Given this list of marker genes Blcap, Bbc3, Fcer1g, Actb, Mrpl17, Furin, Hspa9, Rps6kc1, Eif2s3x (NCBI Gene Id 26905), Ctrc, Frmd8os, Lrrfip2, Xpnpep3, Casp4 (caspase 4, apoptosis-related cysteine peptidase, NCBI Gene Id 12363), Mir1931, Sirt6, Sema4a, C030005K06Rik, Gsr, Lyrm1, Zkscan5, Smarca5, Ticam2, Tbck, Snord13, Hivep1, Nfkbia, Slc2a3, Niban3, C1qc, Pno1, Gata3un, Tgif1, Eif4g2, Napsa, Tpbg, Relb, Plscr1, Zmiz1os1, Ptgs2os, Arid5b, Osgin1, Ddx31, Gm16794, Zfp811, Tnfaip8, Sh3bp5l, Mir8105, Olr1, Clec4e, Cnbd2, Gbp6, Cactin, Thbs1, B430010I23Rik, Rmrp, Gm13986, Tm9sf1, Ccnl1, Mnt, Med13, Ifnb1, Utp3, Trps1, Nod2, Gch1, Uqcrc2, Gbp4, Dennd4a, Zbtb18, Opa3, Lrmda, 4931440P22Rik, Fadd, Itgb5, Pdap1, Tubgcp4, Atp5mc1, Il2rg, Adgre1, Ccni, Ogfr, Adamts4, Kcnh4, Tnip3, Ikzf4, Ubl7, Lmna, Manbal, Mir155hg, Slc29a1, 4930592C13Rik, Txlnb, Tfeb, Creg2, Zfp429, Zfp91, Ist1, Tnip1, Plpp1, Itpkc, Sephs2, Eif4enif1, Srd5a1, Kat2b, Pcdh7, Gm7804, Neurl3, Mir6236, Tnfsf13, Prex1, Iqcg, Ptch1, Oip5, Igsf6, Zbtb21, Gm27003, Ank1, Pak1ip1, Mideas, Bud31, Lrrc49, 9130230L23Rik, C3, Lrrc63, Slc30a6, Ptges, Etv6, Irak3, Hectd1, Cacybp, Acaa1a, Tmem39a, Golga5, Zc3h7a, Csf1r, Cox18, Ric8a, Zc3h12a, Anp32a, Irgq, Actr2, Rbm47, Gramd1b, Slc35b1, Phf14, Prdx6, Ccl6, Eml6, Hk1, Gm16675, Eftud2, Hif1a, Pan3, Il3ra, Cited2 (Cbp/p300-interacting transactivator, with Glu/Asp-rich carboxy-terminal domain, 2), Myef2l, Tcf4, Gm26608, Bet1l, Sec23b, St3gal3, Zscan29, 1810062G17Rik, Slc2a6, Gm6209, Hcar2, Pvt1, Kmt5c, Nudt9, Aebp2, Rabggtb, Gm5617, Oxsm, Gbp7, Kmt2b, Gramd4, Mir1932, Capza2, Pigv, Nfe2l1, Etfb, Mettl27, Sema4d, Ajuba, Nktr, Tm2d1, Eny2, Dop1b, Maff, Treml4, Rbbp5, Grcc10, Gm11788, Atg16l2, Rela, Aimp1, Adhfe1, Mt2, Lrr1, Srsf5, 9130401M01Rik, Supv3l1, Ccdc103, Spred1, Dtx4, Hmcn2, Rnf213, Efcab9, Zranb2, Gtf3c6, Ext1, Polr2h, A830008E24Rik, Smim30, Arl6ip5, Ptp4a1, Igsf9, Snora24, Rnf38, Ctdspl2, Ptpn3, Nlrp3, Orai2, Clec4a1, Pgghg, Grk3, Scarna2, Zfp740, Ehd1, Lrrc8c, Ttc39d, Nme1, Cfap43, Rbm43, Nab2, Stat5a, Mrpl11, Psmd9, Ier2, Gorab, Kctd9, Hmg20a, Zfp800, Il23a, Rab11fip1, Ppm1h, Cul3, Alg9, Ccl12, Slpi, Gbp8, Nadk, Gtf3c4, Saa3, Gm11527, Lcn2, Tank, Oas3, Ccdc107, Selenof, Slc37a3, Wrap53, Lnpk, Arhgap21, Aldh3b1, Birc3, Cdk4, Denr, Naa50, Klhdc10, Mcur1, Il1rn, Mir374c, Synpo, Ifrd1, Ktn1, Ccin, Tnfsf9, Dbt, Clic5, Pcbp1 (NCBI Gene Id 23983), Mrtfa, Bend6, Gm6665, Cxcl10, Aoah, Snord45c, Cd86, Kmt2e, Gm5475, Tnfaip2, Dph6, Tm9sf4, Tti2, Rigi, Gbp9, Tnfaip3, D930030I03Rik, Plcxd2, Ksr1, Nhlrc3, Nfatc1, Rnu11, Zdhhc21, Katnb1, Itga5, Eapp, Tal1, Ift74, Nek8, Gm25703 (predicted gene, 25703), Nfkbiz, 2410002F23Rik (RIKEN cDNA 2410002F23 gene), Usf1, Tonsl, Mrpl52 (NCBI Gene Id 68836), Gm37294, D16Ertd472e, S100a4, Kif11, Pdzk1ip1, Fchsd2, Pdxk, Neat1, Gm15663, Spaca6, 4930445N08Rik, Cdnf, Oasl1, Plekha4, Tsacc, Arap1, Tnfsf4, Il1b, Adgrg6, Acox3, Ptgs2, Fam110a, Tbc1d13, Trim13, Nrg4, Septin9, 2310044K18Rik, Amz2, Zc3hav1, Rab5if, Acod1, Ptgs2os2, Bnip3l, Gm20655, Sbf2, Pan2, Parp3, Hamp, E330011M16Rik, A730081D07Rik, Nuggc, Dmwd, Tex48, Bach2it1, Hmgcr, Psme3, H3f3b, Nub1 (NCBI Gene Id 80634), Tarm1, Slfn2, Zfp335, Elk3, Cd74, 1600020E01Rik, Rapgef2, Smpdl3b, Relt, Ndufa4, Ddx60, 9930022D16Rik, Fli1, Mccc2, Il1r2, Peak1, Gm11346, Capg, Wsb2, Nr1d1, 2810454H06Rik, 6030442K20Rik (RIKEN cDNA 6030442K20 gene), 4930580E04Rik, 4932441J04Rik, Alyref2, Snord118, Lemd3, Lgi4, Rcbtb2, Gabpb1, Clcn2, Klhl3, Spa17, Actr3, Rexo1, Rpl7, Ccdc50, Atg10, Nfkbib, Htra1, Mfsd13a, Ralgds, Gm8013, Slc36a1os, Mdfic, Trappc3, Hgf, Mir7009, Pwp1, Pdzd9, 2010016I18Rik, Il4i1, Sppl2a, Dennd2d, Proser1, Fzd7, Dnaaf10 (NCBI Gene Id 216540), Mtmr14, Tmbim4, Ikbke, Ckap2l (cytoskeleton associated protein 2-like), Gpr19, Etv1, Cxcl2, Acss2, Chd2, Ube2j2, Trex1, Acsl1, Creb1, Smim10l1, Erbin, Btbd19, Rpl35a, Cyld, Stk40, Ube2m, Bcl2a1c, Srsf7, Tob2 (NCBI Gene Id 73089), Ppp4r2, Tmem9b, Atxn7l1, Gbp10, Aff1, Tbc1d4, Ak4, Man1a, Serpina3f, Abca1, Rrp9, C5ar2 (NCBI Gene Id 319430), Kdm5c, Cpeb3, Enthd1, Nfkb1, Arhgap11a, Ndufs7, St13, Trp53, Sptan1, Gna13, Smarcc2, Mpc1, Cltc, Slc15a3 (solute carrier family 15, member 3), Cdca2, Hs2st1, Gadd45b, Sirt2, Sdc4, Lcp1, Haus8, Tmem63b, Retreg1, Ube2e1, Itga4 (integrin alpha 4), Herpud1, Elmod2, Hjurp, Rarg (NCBI Gene Id 19411), Ccl3, Lhpp, Snx10, Ttc19, Gbp2, Lat2, Pik3r5, Ice1, Ctsl, Acp3, Traf1, 5031425E22Rik, Gas7, Gmfg, Sphk1, Ebi3, Fyb1, St7, Kit, Gpr85, Hk1os, Snf8, Calm1, Gm26725, Atg9a, Agrn, Lamtor3, Mageb3, Myo1c, Zfp180, Nsun2, Ccl17, Rsad1, Cfp, Stx11, Stk10, Cd40, Gbp3, Trim56, Cs, Gbp5, Slc7a11, Cd70, Lair1, Tmem192, Nfkb2, Vcan, E230016K23Rik (RIKEN cDNA E230016K23 gene), Malt1, Mcemp1, Ppp2r2d, Atf5, Eif1ad, Gpr84, Snhg8, Cd44, Coq7, Serpinb2, Slc39a4, Smpd3, Spag9, Gm26535, Atp6v1a, Il10ra, Il7r, 6720483E21Rik, Kmt5b, Csf3, Plekhg2, Ppm1a, Atxn1, Smg7, here is a description of the gene set: Genes containing one or more binding sites for (Rel) in their promoter regions (TSS -1000,+100 bp) as identified by GTRD version 20.06 ChIP-seq harmonization. species: Mus musculus from publication Yevshin I, Sharipov R, Kolmykov S, Kondrakhin Y, Kolpakov F (PMID 30445619) Mouse Gene Set: REL_TARGET_GENES